The following is a description of a gene set: Myoclonus Human Gene Set: HP_MYOCLONUS species: Homo sapiens Very brief, involuntary random muscular contractions occurring at rest, in response to sensory stimuli, or accompanying voluntary movements., and this is the list of marker genes: CYFIP2, STAMBP, GABRG2, THAP1, PPP3CA, PRDX3 (NCBI Gene Id 29017), FBXO28, SDHD, NTNG1, SPTAN1 (spectrin alpha, non-erythrocytic 1), PLCB1, MT-CO2, GNAO1, SOX10, GUF1 (NCBI Gene Id 60558), PIGP, ADSL, ATXN2, PACS2, CNPY3, CLN6, AKT1, SLC2A3, CLN5, GABRB3, MECR (mitochondrial trans-2-enoyl-CoA reductase, NCBI Gene Id 554211), GRIN2B, GRIN2A, TRAF7, AFG3L2, SLC6A5, SLC2A1, PCDH19, AKT3, MOCS2, RMND1, RORA, SCN8A, TREM2, TOE1, SLC25A19, MT-TQ, CASK, MT-ND1 (NCBI Gene Id 4535), SCN2A, PDGFB, POLG, KCTD7, ANO3, GOSR2, APOE, ATP1A3, PIGW, PODXL, CCDC88A, CTNND2, GABRB2, COG8, PIGQ, CASR, TRAK1, OCA2, CARS2, CRELD1, NARS1, CTSF, SUCLG1, EFHC1, MT-TI, SCN1B, CNTN2, NDUFAF3 (NADH:ubiquinone oxidoreductase complex assembly factor 3), GRIK2, ITPR1, KCTD17, DDC, MAPT, MRAP, MT-ND6, CLCN2, MT-TH, MT-TW, GFAP, NPTX1, SLC1A4, CIC, FZR1, AP3B2, NHLRC1, YEATS2, JRK, MT-ND4, TH, GCSH, KCNA1, PRICKLE1, GNA11, NEUROD2 (NCBI Gene Id 4761), GRIN2D, ATP6V0A1, FRRS1L, MOCS1, GLRB, PDHA1, SMC1A, NUP214, NFASC, PSEN1, CACNA1H, MECP2, BOLA3, PGAP3, SGCE, CYP27A1, FARS2, SERPINI1, TSPOAP1, COQ8A, MT-TK, JAG1, GRIN1, SLC25A10, CACNB4, CHMP2B, PTS, FOXRED1, HTT, CELF2, NDUFA1, HACE1, ATP6V1B2, KIF5A, SCARB2, PRKCG (NCBI Gene Id 57013), ADCY5, PLPBP, KCNB1, PRRT2, NKX2-1, TSPYL1, MT-CO1, WDR45, CACNA1B, VPS13D, SIK1, NECAP1, GLRA1, SZT2 (NCBI Gene Id 79597), DHDDS (dehydrodolichyl diphosphate synthase subunit), LMNB2, CHD2, NUS1, UBE3A, KCNA2, NFU1, FOXG1, TEFM (transcription elongation factor, mitochondrial), SDHA, HCN1, MINPP1, SLC13A5, KCNQ2, GLDC, GAMT, PRDM8, SC5D, CLCN4, PIGL, SCN3A, TBC1D24, NHLRC2, NOL3, TPP1, SCO2, ADAR, PIGO, TRAPPC12, NUP62, SMS (NCBI Gene Id 6735), NGLY1, ZNHIT3, YRDC, DHFR, SYNGAP1, SUFU, SMO, ABCB7, ATN1, RAPGEF2, NDUFV1, TERT, GALC, ABCA7, QDPR, DALRD3, CLN8, DTYMK, MT-TS2, TYROBP, NAGA, TOR1A, PSAP, DNAJC6, NTRK2, HEXB, LMO1, ATAD1, SAMD12, MT-ATP6, FTL, PSAT1, ATP6V1A, TXN2, TBP, LIAS, WWOX, COQ5, SLC6A1, CACNA1A, TWNK, CIZ1 (NCBI Gene Id 25792), APP (amyloid beta precursor protein), HLA-DQB1, UFC1, CRLS1, MT-TL1, BSCL2, CNKSR2, SATB1, PPT1, HNRNPU, ALK, PGAP2, EEF1A2 (eukaryotic translation elongation factor 1 alpha 2), PNPO, PURA, PIGA, ARX, PLA2G6, LIG3, BAP1, CUX2 (cut like homeobox 2), GABRA2, CDKL5, AARS1, MT-TP, COQ2, TIMMDC1, DMXL2, NOP56, GLRX5, MT-CO3, SYNJ1, KIF1B, SLC25A46, SORL1, RFT1, ST3GAL5, POLR1A, BRAT1, MYCN, SNCA, DNM1 (dynamin 1), CACNA2D1, AFF3, CPLX1, KCNC1, CSTB, CLPB (ClpB family mitochondrial disaggregase), CERS1, TNRC6A, EPM2A, SCN1A, YWHAG, SEMA6B, PIGY, PET100, ST3GAL3, NDUFA4, SLC25A22, RORB, SLC7A6OS, ADRA2B, CLTC, MTPAP, LIN28B, TOMM40, VPS41, SMARCB1 (SWI/SNF related, matrix associated, actin dependent regulator of chromatin, subfamily b, member 1, NCBI Gene Id 6598), DENND5A, KMT2B, MARCHF6, PRNP, CLN3 (NCBI Gene Id 1201), IRF4 (interferon regulatory factor 4), DNAJC5, GRM7, GABRA1, FGF12, SLC1A2, GABRD, TAF1, AP2M1, POMGNT1, AHDC1, MRE11, GABBR2, CDK19, POLR1C, DAB1, NEU1, KCND3, ACTL6B, PIK3CA, GLB1, ASAH1, VPS53, MT-ND5, ATP1A2, KCNQ3, SLC32A1, TRIM8, STX16, GRIA3, PTCD3, NAXD, DRD2, ATM, ATP13A2, MT-TF (mitochondrially encoded tRNA-Phe (UUU/C)), GNAS, PHACTR1, HMGCL, GLYCTK, CACNA1E, INPP5E, SLC38A3, EIF2AK2, MAPK10, DOCK7, GNB1, PI4K2A, PSEN2, COX4I1, UBA5, STARD7, KCNC3, GABRA5, MTOR, GPHN, PARS2, NF2, GBA1, TSEN54, FBXO7, ELOVL5, KIF1C, SMARCE1, AP5Z1, PHOX2B, SLC25A12, NUP54, CILK1, PGM3, HIBCH, FRMD5, ABCD1, KCNC2, PNKP, PIGV, SCN9A, KCNN2